The following is a description of a gene set: studied in species Mus musculus Genes predicted to be targets of miRBase v22 microRNA mmu_miR_744_5p in miRDB v6.0 with MirTarget v4 prediction scores > 80 (high confidence targets). from publication Chen Y, Wang X (PMID 31504780) Mouse Gene Set: MIR_744_5P, and this is the list of marker genes: Sh3bgrl3, Rad51, Nfix, Upf1, Pax2, Aplf